The following is a description of a gene set: part of: SLC transporter disorders The human SLC22A5,15 and genes encode for sodium-dependent, high affinity carnitine cotransporters which maintain systemic and tissue concentrations of carnitine. Carnitine is essential for beta-oxidation of long-chain fatty acids to produce ATP. SLC22A5 encodes the organic cation/carnitine transporter 2 (OCTN2). SLC22A5 is strongly expressed in the kidney, skeletal muscle, heart and placenta. Defects in SLC22A5 are the cause of systemic primary carnitine deficiency (CDSP; MIM:212140), an autosomal recessive disorder of fatty-acid oxidation caused by defective carnitine transport resulting in cardiac, skeletal, or metabolic symptoms. If diagnosed early, all clinical symptoms can be completely reversed with a carnitine supplement. However, if left untreated, patients will develop lethal heart failure. Reactome Pathway: Defective SLC22A5 causes systemic primary carnitine deficiency (CDSP) species: Homo sapiens, and this is the list of marker genes: SLC22A5